Given this list of marker genes Cep152, Plk4, Sass6, Deup1, Ccdc78, Cdc20b, here is a description of the gene set: studied in species Mus musculus Mouse Gene Set: GOCC_DEUTEROSOME A spherical, electron dense, cytoplasmic structure that is involved in de novo assembly of centrioles.